The following is a description of a gene set: part of: Class I MHC mediated antigen processing & presentation Reactome Pathway: Antigen processing: Ub, ATP-independent proteasomal degradation This event has been computationally inferred from an event that has been demonstrated in another species.<p>The inference is based on the homology mapping from PANTHER. Briefly, reactions for which all involved PhysicalEntities (in input, output and catalyst) have a mapped orthologue/paralogue (for complexes at least 75% of components must have a mapping) are inferred to the other species. electronically inferred by orthology from the curated human pathway species: Mus musculus, and this is the list of marker genes: Psme2, Psmb7, Psme1 (proteasome (prosome, macropain) activator subunit 1 (PA28 alpha)), Psmb9, Psma2, Psmb4 (proteasome (prosome, macropain) subunit, beta type 4), Psmb8, Psma5, Psmb5, Psma6, Psma1, Psma3, Psma7, Psma4, Psmb6, Psmb10